Given this list of marker genes Tfrc, Selenow, Prss34, Kctd5, Ybx2, Atp13a3 (NCBI Gene Id 385637), Tysnd1, Rpap2, Erbb4, Inava, Umodl1, Slc38a1, Efr3b, Zfp275, Chd9, Ctdspl2, Pbx3, Cnot11, Sod3, Wdr72, Atxn1, Enpep, Kifap3, Caln1, Klf1, Ndst2, Mocs3, Emcn, Nedd9, Kdm2a, Ago1, Rc3h2, Csmd3, Sgip1, Hdgf, Dhrs7b (dehydrogenase/reductase 7B), Fbxo42, Tfcp2l1, Cysltr1, Cul4b, Ywhag, Arhgap44, Clip3, Syt6, Vps25, Actr1a, Chd3, Cyp4a14, Mtss1, Cinp, Bend4, Lypd3, Sun2, Trim39, Herc3, D630045J12Rik, Rab11fip2, Hao1, Hook3, Bmp15, Pbsn, Usp31, Usp30, Pof1b, Igf2bp2, Tspyl5, Rbm15b, Cd2bp2, Poldip3, Adra1a, Phf11, Fn1, Dclk1, Dcun1d4, Dcx, Dlgap1, Arhgef3, Tmed9, Hnrnpa3, Scin, Cdc42bpa, Vezt, Ube3a, Ppm1d, Gm9, Ifnlr1, Ciao1, Ino80d, Tmc2, Cldn1, Gopc, Slco2b1, Unkl, Plac8l1, Zfp866, Pear1, Rasl10b, Onecut2, Nsd2, Ywhaz, Ripor2, Ncbp2, Fam163b, Sf3b2, Ccnc (cyclin C), Tub, Or6d12 (olfactory receptor family 6 subfamily D member 12), Zfp729a, Hapln1, Atg4c, Pdk4, Tnrc6b, Zfp563, Rs1, Kprp (NCBI Gene Id 99519), 5430402E10Rik, Sepsecs, Nwd2, Trim35, Zfp971, Phf20, Cyb5a, Ptov1, Pla2g4c, Odad1 (outer dynein arm docking complex subunit 1, NCBI Gene Id 211535), Tatdn3, Bmal1 (basic helix-loop-helix ARNT like 1), Inpp4a, Ergic1, Mis18bp1, Faxc, Mbd2, Strada, Dpm1, Rab28, Hltf, Clip1, Epyc, Steap2, Dgkb, Ei24, Dpysl3, Ttpal, Creb3l2, Hdx, Tafa5, Ccdc86, Cdh3, Slc25a40, Trabd2b, Tmbim7, Gpr141b, Hecw1, Krtap10-10, Gm1553, Rad54l2, Ercc1, Fgd5, Mapk10, Ostm1, Gpr158, Pabir2, Tigd3, Zfp141, Serpinb9b, Gm14744, here is a description of the gene set: Mouse Gene Set: MIR_6959_5P studied in species Mus musculus Genes predicted to be targets of miRBase v22 microRNA mmu_miR_6959_5p in miRDB v6.0 with MirTarget v4 prediction scores > 80 (high confidence targets). from publication Chen Y, Wang X (PMID 31504780)